The following is a description of a gene set: Catalysis of the reaction: an alcohol + NADP+ = an aldehyde or a ketone + NADPH + H+. Mouse Gene Set: GOMF_ALDO_KETO_REDUCTASE_NADPH_ACTIVITY studied in species Mus musculus, and this is the list of marker genes: Kcnab1, Akr1c6, Dhrs2, Dhrs1, Akr1c21 (aldo-keto reductase family 1, member C21), Akr1b10, Rdh14, Miox, Aldh3a1, Cbr2, Dhrs4, Cbr3, Akr1c18, Kcnab3, Akr1cl, Dhrs7l, Akr1c13, Rdh10, Dhrs3, Akr1d1, Akr1b7, Akr1c19, Cbr1, Akr1e1, Kcnab2, Akr1a1, Dhrs7, Akr1b1, Akr1c20 (aldo-keto reductase family 1, member C20), Akr7a5, Akr1c14, Akr1c12, Adh4, Akr1b8, Rdh12, Dcxr, Rdh13, Cbr1b, Rdh11